Given this list of marker genes ABHD2, SH2D5, LPAR2, SLC35D3, LRRC75A, RBM26, RAG2, CHCHD10, INTS6 (NCBI Gene Id 26512), SLC29A3, CSF1R, SORL1, CCR9, PIERCE1, PLEKHA2, ADGRG3, RNF123, TMPRSS3, KRT28, ZC3HAV1L, HAL, CDT1, PIP4K2A, CACNB1, RASGRP3, CD93, UBE4B, SELPLG (NCBI Gene Id 6404), WNK1, PROB1, MED1 (mediator complex subunit 1), LGI3, RALGPS1, CENPN, RC3H1, CFL1, GPATCH8, AKNA, IPCEF1, TEX9, STING1, COPS7B, DYRK2, AP1S2, CNP, XPO7, KBTBD11, CDS1, ULK4, SMARCC1, CD244, EWSR1, RBP7, CHST15, UMPS (NCBI Gene Id 7372), PDS5B, HOXD9, SRRM2, RBP2, CD53, CD52, VPREB3, SCAP, VPREB1, PGR, DNAJC6, FADS6, MGST2, SLFN13, IWS1, NOTCH1, TCF19, IL2RA, HLA-DOB, TULP4, AFF3, SEMA4D, IL7R, FOXO1, PAOX, BIRC6, PIK3AP1, CUX1, CLCN3, MCC, HMGA2, ICOS, HCN1, TCN2, TNFAIP1, KXD1, BCL2L11, SGO2, CPSF7, HGH1, NLRC3, MDC1 (NCBI Gene Id 9656), ZNF397, FAM167A, MN1, MAP3K5, GAL3ST1, WDFY4, IGLL1, ZNF706, FAM78A, CHFR (checkpoint with forkhead and ring finger domains), TIMELESS, DAP, EPHA2, MYH1, INCENP, DNTT, GPSM1, CEP128, RHBDL3, SLC7A1, EBF1, PCP4, APCS, ITGAL, CAMKV, TCF4, PRKCB, ATP10A, GRAMD2B, ELOVL6, CD33, TMEM268, GPR25, POLD1, RSPO4, CRACDL, BANK1, CTNND2, DNASE2, CTU2, JPT1 (NCBI Gene Id 51155), CARD11, CST7, TACC2, CIMAP1A (ciliary microtubule associated protein 1A), COL19A1, UBP1, NUCB2, MPO, TAOK1, TTC13, IRAG1, ST8SIA1, LY6D, TENT4B, SH3BGRL3, SEMA4A, PCDH9, ATXN2, HCN2, MXRA7, PTGDR2, CYB561A3, TRAF4, SLC43A3, PKIG, ENC1, REEP5, TRIP11, CAMKK2, TRIM28, LPAR1, CD79A, DHX30, SAPCD1, CRYBG3, BMP2K, NAT8L, C21orf91, TRAF3IP2, SLC38A2, GPR158 (G protein-coupled receptor 158), SRPK1, SLC25A53, FBXL16, BTNL9, TET1, BACH2, MED13L, HNRNPU, SATB1, CD44, IL1R1, ATP8B4, TIFAB, KIAA0930, CAP1, PEAK1, DHRS3, PPARD, CNTD1, APCDD1 (APC down-regulated 1), here is a description of the gene set: CpG 1826 binds to Toll-like receptor (TLR)9, whereas influenza virus PR8 activates pDC via TLR7. Differential stimulation of pDCs is expected to result in unique activation mechanism(s) leading to a different phenotypically and functionally matured pDC We used microarrays to detail the global programme of gene expression underlying the maturation process of pDC activated with CpG 1826 and influenza virus PR8. We identified a distinct expression profile of upregulated immunomediators. Genes down-regulated in plasmacytoid dendritic cells in response to influenza virus infection: 1h versus 4h. species: Homo sapiens Human Gene Set: GSE7831_1H_VS_4H_INFLUENZA_STIM_PDC_DN from publication Iparraguirre A, Tobias JW, Hensley SE, Masek KS, Cavanagh LL, Rendl M, Hunter CA, Ertl HC, von Andrian UH, Weninger W (PMID 18029397)